Given this list of marker genes NXPE3, ZNF33A, SUSD6, FAM199X, KLHL23, SLC18A2, ONECUT2, SESN3, DYNLT1, THAP2, PRKAR2A, CNTN5, RBMXL2, NR4A3, IPO7, ELMOD2, SLC5A8, HIPK3, SOCS5, MEF2C, GOLPH3, PAQR6, IRF2BPL, VSTM2A, RNF220, TSHZ3, ATP1B1, ZFX, FECH, ARHGAP20, MYNN, USP25, IKZF2, GNG5, RIPK2, NFASC, MFSD4A, ANKRD12, LAMC1, ABCA10, ITGAV, PDGFC, PIP4P2, GFM1, CPEB3 (cytoplasmic polyadenylation element binding protein 3), FSTL1, KCTD10, TRPS1, MOB1A, SGMS2, STXBP5, DOCK7, BRD1, CDCA7, PI4K2B, MOSMO, CLINT1, SEMA6D, CREBZF, REST, YPEL2, EXPH5, PTPRB (protein tyrosine phosphatase receptor type B), DOCK11, GBX2, ZBTB43, BTG2, ZFAND6, CCDC83, DCAF17, BRD3, ZZZ3, GOLGA8N, SMC5, ZFAND5, SAMTOR, KLHL36, ZNF184, TNRC6B, ACBD5, AXIN1, USP13, ZNF143, ECM2, SEZ6L, ARIH2, NRN1L, SNX27, here is a description of the gene set: studied in species Homo sapiens Genes predicted to be targets of miRBase v22 microRNA hsa-miR-6782-3p in miRDB v6.0 with MirTarget v4 prediction scores > 80 (high confidence targets). Human Gene Set: MIR6782_3P from publication Chen Y, Wang X (PMID 31504780)